The following is a description of a gene set: Increased thumb width without increased dorso-ventral dimension. Human Gene Set: HP_BROAD_THUMB species: Homo sapiens Broad thumb, and this is the list of marker genes: OTUD6B, GATA4, DVL1, PACS1, CBFB, TBX5, GPC3, DVL3, MAP3K7, GNAS, LMBR1, ACAN, FGF9, DHX30, COL2A1, ADNP, TRPM3, FLNA, DNM1L, H3-3A, HOXD13, IFT56, SALL1, RLIM, BPTF, FGFR2, GJA8, GDF5 (growth differentiation factor 5), CHST3, MEIS2, GJA5, PRKG2, EZH2, MAN2C1, XYLT1, EP300, ROR2, BICRA, MED12, OFD1, ZNF668, RBM8A, PRKD1, GLI3, EED, B3GALT6, SIAH1, SRCAP, BMP2, PSMD12, RERE (arginine-glutamic acid dipeptide repeats), PYCR2, FGFR3, CREBBP, KCNH1, KCTD1, MSX2, USP9X, TWIST1, SUMF1, DACT1, PCDHGC4, SATB2 (SATB homeobox 2), ALX4, PUF60, SUZ12, INPPL1, HPGD, NSD1, GPC4, G6PC3, EXOSC2, PTEN, SMOC1, H3-3B, NSUN2, POGZ, SMO, RAB23, B3GAT3, FLNB, NXN, WNT5A, NOG, FGFR1, MEGF8, HNRNPR, LIG4, SNIP1, BMPR1A